Given this list of marker genes TKT, HK3, RPTOR (regulatory associated protein of MTOR complex 1), HK2, ALDOB, RBKS, G6PC3 (NCBI Gene Id 92579), HKDC1, GCK, TIGAR, H6PD, RPE, RPEL1, MTOR, HK1, PRPS2, TALDO1, G6PC1, G6PC2, PGD, RPIA (ribose 5-phosphate isomerase A), SHPK (NCBI Gene Id 23729), ACACB, DERA (NCBI Gene Id 51071), MLST8, NFE2L1, GPI, TP53, PGLS, G6PD, here is a description of the gene set: species: Homo sapiens The chemical reactions and pathways involving glucose 6-phosphate, a monophosphorylated derivative of glucose with the phosphate group attached to C-6. Human Gene Set: GOBP_GLUCOSE_6_PHOSPHATE_METABOLIC_PROCESS